Given this list of marker genes BRAF, EPAS1, SDHD, KIF1B, ANKH, DKK1, COCH, GJA1, SDHA, KARS1, TMEM127, OTX2, CHD7, CA2, TNFSF11, NF2, NFU1, SLC29A3, SLC52A3, TMEM53, SMARCB1, CDKN1A, CDKN2C, USP8 (NCBI Gene Id 9101), PRRT2, LRP4, HNRNPA1, COL4A1, NR3C1, SDHB, NF1, CDKN2B, CLCN7, NOD2, SDHC, GDF6, DNMT3A, MTRFR, FH, TCIRG1, MDH2, SPRED1, LZTR1, CCM2, HNRNPA2B1, FGF3, MAX, VCP, CDKN1B, EGR2, SEMA3E, SCN1A, SDHAF2, ATP1A2, CACNA1A, GNAQ, TNFRSF11A, RET, COQ6, MEN1, PRRX1, USP48, ATRX, SLC25A11, PIK3CA, KRIT1, HRAS, TP53, TGFB1, GDF3, VHL, SNX10, CDH23, MEOX1, DLST, PLEKHM1, SH3TC2, PDCD10, here is a description of the gene set: Abnormal cranial nerve morphology Structural abnormality affecting one or more of the cranial nerves, which emerge directly from the brain stem. studied in species Homo sapiens Human Gene Set: HP_ABNORMAL_CRANIAL_NERVE_MORPHOLOGY